The following is a description of a gene set: from publication Yao MW, Lim H, Schust DJ, Choe SE, Farago A, Ding Y, Michaud S, Church GM, Maas RL (PMID 12554760) species: Mus musculus Human Gene Set: YAO_TEMPORAL_RESPONSE_TO_PROGESTERONE_CLUSTER_16 Human infertility and recurrent pregnancy loss caused by implantation defects are poorly understood. Hoxa-10-deficient female mice have severe infertility and recurrent pregnancy loss due to defective uterine implantation. Gene expression profiling experiments reveal that Hoxa-10 is an important regulator of two critical events in implantation: stromal cell proliferation and local immunosuppression. At the time of implantation, Hoxa-10 mediates the progesterone-stimulated proliferation of uterine stromal cells. Hoxa-10 mutants express a stromal cell proliferation defect that is accompanied by quantitative or spatial alterations in the expression of two cyclin-dependent kinase inhibitor genes, p57 and p15. Hoxa-10 deficiency also leads to a severe local immunological disturbance, characterized by a polyclonal proliferation of T cells, that occurs in place of the normal progesterone-mediated immunosuppression in the periimplantation uterus. Genes co-regulated in uterus during a time course response to progesterone: SOM cluster 16., and this is the list of marker genes: COL6A2, CALM3, COL6A3, CYP51A1 (cytochrome P450 family 51 subfamily A member 1), ANXA6, TUBB4A, FBN1, ACTN1, SQLE, PYGM, KDELR3, IDI1 (isopentenyl-diphosphate delta isomerase 1), AGR2, GPX7, CRABP1, TMEM45A, CAVIN3, AKT1S1, PCDH7, AQP4, VCAN, DBN1, REXO2, BZW2, GAPDH, NPDC1, BCL7C, C1QTNF12, COL4A1, CRTAP (NCBI Gene Id 253263), MAOA, MRPS25, MSMO1, TP53, BGN, TNNT2, PCOLCE, COL3A1, P3H3, TNNI2, SARDH, DAB2, COL18A1, PTGER3 (NCBI Gene Id 5733), SH3BGR, DMPK, NME4, IGKV1-16, MEST, GUSB, FEZ1 (fasciculation and elongation protein zeta 1), SMOC2, NPNT, SPARC, CNN1, COL1A2, PDLIM7, PFN2, MFAP2, AOC3, PRAF2, WDR6, ADAM15, FADS1, CLVS1, TFPI, PCP4L1, COL4A2, HNRNPDL, STRA6, COLGALT1, NDP, FEZ2, SRPX, COL1A1, NPTX2, IGFBP5 (insulin like growth factor binding protein 5), ACTC1, FABP5